Given this list of marker genes UQCC2, UQCC6, STMP1, LYRM7, SLC25A33 (NCBI Gene Id 84275), UQCC4, UQCC5, UQCC1 (NCBI Gene Id 55245), UQCC3, TTC19, FXN, UQCRFS1, BCS1L, here is a description of the gene set: species: Homo sapiens The aggregation, arrangement and bonding together of a set of components to form the cytochrome bc(1) complex, a transmembrane lipoprotein complex that it catalyzes the reduction of cytochrome c by accepting reducing equivalents from Coenzyme Q, by the aggregation, arrangement and bonding together of its constituents. Human Gene Set: GOBP_RESPIRATORY_CHAIN_COMPLEX_III_ASSEMBLY